Given this list of marker genes PAX8, PKD2, PKD1, PAX2, CALB1, POU3F3, UMOD, here is a description of the gene set: Human Gene Set: GOBP_METANEPHRIC_DISTAL_TUBULE_DEVELOPMENT The process whose specific outcome is the progression of the metanephric distal tubule over time, from its formation to the mature structure. The metanephric distal tubule is a metanephric nephron tubule that begins at the metanephric macula densa and extends to the metanephric connecting tubule. species: Homo sapiens